Given this list of marker genes Tbr1, Ap1s2, Atp1a3, Adam2, Srf, Elavl4, Ppt1, Ctns, Tsc1, Kras, Slc6a4 (solute carrier family 6 (neurotransmitter transporter, serotonin), member 4), Drd1, Nptx2, Atp1a2, Csmd1, Pianp, Tuba1a, Shank1, Idua, Clstn2, B4galt2, Hif1a, Rgs14, Cacna1e, Neurod2, Ddhd2, Lrrn4, Comt, Drd3, Crh, Cln8, Cln3, Htt, Pde1b, Oprk1, Glp1r, Cdk5, Hrh1, Kit, Specc1, App, Shank2, Deaf1 (NCBI Gene Id 54006), Nog (noggin), Snap25, Abcc8, Mup20, Shank3, Atxn1, Slc6a1, Fos, Tpbg, Cacna1c, Hmgcr, Dbh (NCBI Gene Id 13166), Slc7a11, Abl2, Pln, Mecp2, Gucy2d, Drd4, Abl1 (c-abl oncogene 1, non-receptor tyrosine kinase), Lgmn (NCBI Gene Id 19141), Cntnap2, Adcy3, Drd2, Ndrg4, Pias1, Gabra5, Nlgn3, Tafa2, Grin1 (glutamate receptor, ionotropic, NMDA1 (zeta 1)), Asic1, Zzef1, Btg2 (BTG anti-proliferation factor 2), Tacr1, Rin1, Chrna7, Brsk1, Agt, Meis2, Chrnb2, Ghrl, Sgk1, Synpo, Creb1, Tac1, Abca7, Rapgef3, Dcdc2a, Mtor, Ckap5, Nf1, Adra1b (adrenergic receptor, alpha 1b), Itgb1, Kmt2a, Reln, Ucn, Pgrmc1, Adrb2, Ift20, Ric8a, Chrd, Foxb1, Tanc1, Map1a, Grin2b, Hrh2, Bdnf, Ppp1r1b, Rag1, Syngap1, Slc1a1, Pde8b (phosphodiesterase 8B), Nts, Drd5, Oprl1, Grin2a, Crhr1, Gria1, Cck, Braf, Grm7, Neto1, Tnr, Nps, B3gat1, Sct, Ttc36, Nptn, here is a description of the gene set: Learning by associating a stimulus (the cause) with a particular outcome (the effect). studied in species Mus musculus Mouse Gene Set: GOBP_ASSOCIATIVE_LEARNING